The following is a description of a gene set: species: Homo sapiens HIV Nef to TNF-NFKB signaling pathway. Pathway ID: N00442. Pathway type: Pathogen. Pathway class: nt06516 TNF signaling. Pathway Definition from KEGG: Nef -> (RIPK1+TRADD+TRAF2/5) -> (TAB1/2/3+TAK1) -> IKK -> NFKBIA -> NFKB Human Gene Set: KEGG_MEDICUS_PATHOGEN_HIV_NEF_TO_TNF_NFKB_SIGNALING_PATHWAY, and this is the list of marker genes: RELA, CHUK, TRADD, TRAF2, NFKBIA (NFKB inhibitor alpha), TAB1, IKBKB, NFKB1, RIPK1, TAB3, MAP3K7, TRAF5, IKBKG, TAB2